The following is a description of a gene set: species: Mus musculus from publication Cui A, Huang T, Li S, Ma A, Pérez JL, Sander C, Keskin DB, Wu CJ, Fraenkel E, Hacohen N (PMID 38057668) Cytokines mediate cell-cell communication in the immune system and represent important therapeutic targets. A myriad of studies have highlighted their central role in immune function, yet we lack a global view of the cellular responses of each immune cell type to each cytokine. To address this gap, the authors created the Immune Dictionary, a compendium of single-cell transcriptomic profiles of more than 17 immune cell types in response to each of 86 cytokines (>1,400 cytokine-cell type combinations) in mouse lymph nodes in vivo. A cytokine-centric view of the dictionary revealed that most cytokines induce highly cell-type-specific responses. For example, the inflammatory cytokine interleukin-1β induces distinct gene programmes in almost every cell type. A cell-type-centric view of the dictionary identified more than 66 cytokine-driven cellular polarization states across immune cell types, including previously uncharacterized states such as an interleukin-18-induced polyfunctional natural killer cell state. Mouse Gene Set: CUI_CDC1_IFNB_RESPONSE_UP Genes positively differentially expressed in cell type: cDC1 (conventional dendritic cell type 1) upon treatment with cytokine: IFN-β in mouse lymph nodes in vivo., and this is the list of marker genes: Samd9l, Sema4f, Usp18, Ube2l6, Nampt (nicotinamide phosphoribosyltransferase), Serpina3f, Trafd1, Sdcbp, Cd53, Pbx1, Usp12, Elac2, Larp1b, Txndc17, Tomm70a, Ifi211, Lims1, Stxbp3, Tmem219, Ccdc86, Psmb8, Gnb2, Cd38, Itm2b (integral membrane protein 2B), Ms4a4c, Tapbpl, Ffar4, Rab11a, Cd86, Psmb10, Cdc42bpg, Gbp9, Dtx3l, Sppl2a, Gca, Plxnc1, Map2k1, Mitd1 (NCBI Gene Id 69028), Tcstv4, Cct3, Slbp, Ogfr, Clic4, Acadl, Cd47, Treml2, Igtp, Max, Ptpn6, Casp3, Ifi213, Ifi27l2a, Usp15, Ppfia4, Trim30d, Eif4e2, Procr, Otud5, Mpp1, Slc4a8, Slfn5, Rasa4, Ifi207, Fcgr4, Phf11b, Serpina3g, Mxd1, Tor1aip2, Lamtor5, Mycbp2, Oas3, Cdh15, Sumo1, Eif2s1, H2-D1, Hat1, Plac8, Jaml, Ifit1, Atp6v1d, Tpm4, Il10ra, Tap2, Ehd4, Pnp, Trim30a, Dcp2, Snx2, Nmi, Litaf, Lgals3bp, Gpr157, Cpne2, Selenot, Ncoa7, Herc6, Dnaja2 (NCBI Gene Id 76342), Slco3a1 (solute carrier organic anion transporter family, member 3a1), Mpc1, H2-K1, Chd1, Ubr4, Gbp2, Ifi205, Fndc5, Cmtm6, Mtmr14, Fbxo4, Cd274, Mov10, Ifi203, Ifitm3, Rufy3, Hnrnph2, Sinhcaf, Bcl9, Dnajc7, Tdrd7, Irf7, Ifi47, Apool (NCBI Gene Id 77997), Npc2, Cst3, Psme2, Sdc3, Prpf38a, Daxx, Hspa5, Frmd4a, Myd88, Fbxw11, Ppm1k, Nufip1, Fyn (Fyn proto-oncogene), Pttg1, Oas1a, Grn, Relb, Stx16, Mthfd2, Ube2l3, Pdia3, Myl12a, Irf2, Nr4a3, Cyp27a1, Epsti1, Lgals3 (NCBI Gene Id 16854), H2-T22, Isg20, Zbp1, Ass1, Scimp, Anxa2, Pmpcb, Rap2a (NCBI Gene Id 76108), Ikzf1, Rnf114, Cd69, Tmbim6, Slfn9, Slc6a6, Nup88, Cmpk1, Zc3h7a, Sem1, Apobec3, Ly6c2, Lgals9, Rigi, Ptms, Prkx, Prr5l, Csprs, Arid4a, Armcx6, Rtp4, Wfdc17, Tcf4, Adap2, Pigf, Brd2, Casp4, Tspo, Spi1, Coq2, Parp14, Ddx24, Cflar, Pdha1, Akt3, Xrn1, Ifi206, Hmgn3, Casp8, Zyx, Dusp5, Nono, Pmepa1, Zfp800 (zinc finger protein 800), Atp6v0a2 (ATPase, H+ transporting, lysosomal V0 subunit A2), Rtraf, Psma3, Fdps, Psmb9, Mndal, Inpp5b, Chmp4b, Oasl2, Nt5c3, Clec9a, St8sia1, Ostf1, Krcc1, Rfc3, Ifi44, Il15, Fgl2, Cd40, Cmpk2, Tex9, Fndc3a, Cybb, Anxa5, Pkib, Prdx1, Tor1aip1, Iigp1, Sell, Dbnl, Snx6, Ifih1, Dok1, Reep3, Slc25a22, Pfkp, Cyrib, Phf11a, Gadd45b, Sct, Nudt9 (NCBI Gene Id 74167), Uba7, Gabarap, Ddx60, Ms4a6b, Samhd1, B2m, Gnb4, Shisa5, Larp1, Trim30b, Sh3glb1, B4galt5, Laptm4b, Cxcl10, Zc3hav1, Cxcl9, Tor3a, Ifit3b (NCBI Gene Id 667370), Csrp1, Ifi204, Selenow, Arpc3, Copg2, Ldha, Ly6e, Cnp, Smarce1, Bcl2a1a, Traf1, C2cd2l (C2 calcium-dependent domain containing 2-like), Qpct, Mbd2, Rcn2, Dnase1l3, Ccnd3, Phf11d, Slfn8, Irgm1, Stard3 (NCBI Gene Id 59045), Il27 (NCBI Gene Id 246779), Ppp1r11, Dek, Tbl1x, Dpy19l1, Sp100, Rab8a, Nes, Psme1, Atp6v1e1, Cd52, Phip, Lpxn, Cited2, Irf5, Ywhah, Tmpo, Pdcd10, Arf4 (NCBI Gene Id 30916), Mx1, Scarb2, Gbp5, Pdk3, S100a6, Dop1b, Morc3, Rel, Isg15, Atp6v1g1 (ATPase, H+ transporting, lysosomal V1 subunit G1), Cfap126, Arpc2, Ifi35, Mcmbp, Ms4a6c, Net1, Wdr43, Ly75, Adar, Ctsc, Helz2, Rnf213, Bst2, Dhx58, Triobp, Rsad2, Tapbp, Sp110, Marchf5, Sfxn1, Ppp1r2, Plekhn1, Dync1i2, Ildr1, Acer3, Ifi209, Chmp5 (charged multivesicular body protein 5), Akr1a1, Parp10, Rap1b, Ly6a, Macir, Bcl2a1d, Stat2, M6pr, Atad1, Txn1, Psma7, Peli1, Svbp, Cycs, Oasl1, Xaf1, Mcl1, Gabarapl2, Flnb, Slc25a25, Tcf7l2, Rnh1, Plscr1, Lap3, Pml, Cd8a, Ccnd2, Il18, Tmem184b, Tmem131, Cntrl, Psma5, Ubc (ubiquitin C), Timeless, Naa20, Tmem51, Zup1, Ifit3, Bbx, Eif2ak2, Gramd2b, H2-T23, Aida, Trim34a, Fbrsl1, Rbms1, Sgcb, Actr2, Slfn2, Cd83 (NCBI Gene Id 12522), Sri, Utp3, Cpne3, Rbm43, Fam241a, Phyh, Cacybp (NCBI Gene Id 12301), Stat1, Znfx1, Sap30, Ube2e1, Eloc, Srsf3, Dck, Dusp2, Ap1g2, Gtf2f1, Gng12 (NCBI Gene Id 72111), Mvp, Atp1b3, Taldo1, Psma4 (NCBI Gene Id 26441), Psma2, Vta1, Ifit2, Ccnd1, Asb2, Clec2d, Slfn1, Bcl2a1b, Ppa1, Vdac2, Usp25, P2ry14, Hk3 (NCBI Gene Id 212032), Anxa7, Gpr33, Tent2, Vdac3, Aldh1b1, Pgap2, Kynu, Vrk1, Phf11c, Nfkbie, Cldnd1, Hdac1, Calm1, Gch1, Armcx3, Fbxw17, Stoml1, Parp12, Fcgr1, Sp140, Gatm, Socs1, Rngtt, Bri3, 9930111J21Rik2, Plaat3, Anxa1, Nlrc5, Anxa4, Med28, Cs, Parp11, Gmppb, Mthfr, Klrk1, Calhm6, Capza2, Dnaja1, Tap1, Ints8, Bag1, Rnf19b, Crlf3, Arpc5l, Plin2 (perilipin 2), Ilrun, Pstpip1, Trim12a, Ndrg1, Tbc1d1, Ccl12, Itga4, Parp9, Laptm4a